The following is a description of a gene set: Hox genes encode transcription factors that control spatial patterning during embryogenesis. To date, downstream targets of Hox genes have proven difficult to identify. Here, we describe studies designed to identify target genes under the control of the murine transcription factor Hoxc8. We used a mouse 16,463 gene oligonucleotide microarray to identify mRNAs whose expression was altered by the overexpression of Hoxc8 in C57BL/6J mouse embryo fibroblasts (MEF) in cell culture (in vitro). We identified a total of genes whose expression was changed by 2-fold or greater: genes were up-regulated, and genes were down-regulated. The majority of genes encoded proteins involved in critical biological processes, such as cell adhesion, migration, metabolism, apoptosis, and tumorigenesis. Two genes showed high levels of regulation: (i) secreted phosphoprotein 1 (Spp1), also known as osteopontin (OPN), was down-regulated 4.8-fold, and (ii) frizzled homolog 2 (Drosophila) (Fzd2) was up-regulated 4.4-fold. Chromatin immunoprecipitation (ChIP) analysis confirmed the direct interaction between the OPN promoter and Hoxc8 protein in vivo, supporting the view that OPN is a direct transcriptional target of Hoxc8. from publication Lei H, Wang H, Juan AH, Ruddle FH (PMID 15699330) Genes up-regulated in MEF cells (embryonic fibroblasts) by overexpression of HOXC8. Mouse Gene Set: LEI_HOXC8_TARGETS_UP species: Mus musculus, and this is the list of marker genes: Emb, Msln, Ccl7, Ly6c1, Ly6f, Cdh11, Il1r2, Ccl2, Raly, Slc16a3, Fzd2, Eif2s3y, Hes2, Srd5a2, Pmp22, Ly6a